The following is a description of a gene set: studied in species Homo sapiens Human Gene Set: MIR1973 from publication Chen Y, Wang X (PMID 31504780) Genes predicted to be targets of miRBase v22 microRNA hsa-miR-1973 in miRDB v6.0 with MirTarget v4 prediction scores > 80 (high confidence targets)., and this is the list of marker genes: IRF2BPL, SHC4, TMEM80, TBX15, ZMYND8, MAFF